The following is a description of a gene set: studied in species Mus musculus Any process that modulates the frequency, rate, or extent of an inflammatory response to an antigenic stimulus. Mouse Gene Set: GOBP_REGULATION_OF_INFLAMMATORY_RESPONSE_TO_ANTIGENIC_STIMULUS, and this is the list of marker genes: Ighg1, Nlrp6, Gpx1, Mkrn2, Gpx2, Zp3, Trem2, Gpr17, Cd81, Tnf, Adcyap1, Spn, Cnr1, Nod2, Pla2g2d, Btk, Il10, Il20rb, Fut7, Fcer1a, Selenos, Ighg2b, Psmb4, Cd28, Fcgr3, Npy5r, Lta, Il12b, Fcgr1, H2-T23, Cd24a, C3, Psma1, Park7, Fcgr2b, Kars1, Fcer1g, Npy, Ccr7